The following is a description of a gene set: part of: Infectious disease Reactome Pathway: Parasitic Infection Pathways Parasitic infection pathways aim to capture molecular mechanisms of human parasitic diseases related to parasite adhesion to and invasion of human host cells and tissues, toxigenicity (interaction of parasite-produced toxins with the human host), and evasion of the host's immune defense.<br><br>Parasitic infection pathways currently include Leishmania infection-related pathways.<br><br>The parasites of the genus Leishmania are blood flagellates transmitted to humans by sandflies. Leishmania causes infections of the skin and mucous membranes that can spread to internal organs (viscera), such as liver, spleen and bone marrow. Visceral leishmaniasis is often fatal. studied in species Homo sapiens, and this is the list of marker genes: IGLV2-8, hly, MAPK1, IGLV1-40 (NCBI Gene Id 28825), IGLV11-55, CD163, VAV2, ELMO1, NOXA1, IGLC1, IGLC2, BAIAP2, IGHV3-7, ITPR2, GNG12, IGLV1-51, GNB2, ARPC2, NLRP3 (NCBI Gene Id 9558), IL1B, ABL1, NCKAP1L, ADCY8, BRK1, IGKV1-17, ADCY9, PRKACG, PYCARD, IGHV4-59, VAV3, CYFIP2, IGKV2-29, WNT5A, ADCY2, NCKAP1, CYBA, GNG5, ARPC3, HMOX1, SUGT1, PRKX, IGKV1-39, ARPC5, ELMO2, CD247, GNG11, PRKAR1B, WIPF3, WASF3, IGLV6-57 (immunoglobulin lambda variable 6-57), ABI1, CYFIP1, IL18, IGKV4-1, IGKV1-12, ARPC1A, ACTG1, CD3G, NFKB2, DVL2, LPG1G2, IGHG2, IGLC7, IGKV1-16, NCKIPSD, TXNIP, ADCY7, GNGT1, IGKV3-20, GNB3, GNG3, ADCY3, IGLV2-33, LYN, PRKACB, ADAM17, JUN, FCGR3A, MYH2, IGKV3-15, IGHV3-13, IGLV1-36, IGLV3-27, IGKV1D-16, NFKB1, CDC42, MYO9B, IGKC, SRC, ITPR1, RELA, GGT5, NOX1, PRKACA, VAV1, FCGR2A, IGLV7-43, IGKV2-28 (NCBI Gene Id 28921), ARPC4, IGKV3-11, P2RX7, AHCYL1, DVL3, GNAI3, WIPF2, FCGR1A, GNB4, DPEP2, GNAI2, IGLV3-12, IGLV5-45, IGHV3-30, IGKV1-33, IL1A, IGHV3-11, GNB1, IGKV1D-12, GNG4, IGLV3-21, CTSG, FYN, MYO5A, HCK (HCK proto-oncogene, Src family tyrosine kinase), NCK1, CREB1, IGLV4-3, ACTR2, RAC1, IGLV3-16, C3, SYK, BTK, GNAS, IGLV1-44, ADCY6, MEFV, FZD7, DPEP1, APP, IGLC6, IGHV4-34, IGLV3-25, YES1, MYH9, ARPC1B, IGKV2D-28, GNGT2, ACTB, IGLV10-54, DVL1, PSTPIP1 (proline-serine-threonine phosphatase interacting protein 1), DOCK1, GRB2, IGHV3-48, PLCG1, FURIN, IGLV3-1, IGHV4-39, MYO10, FGR, ABI2, IGKV1D-33 (immunoglobulin kappa variable 1D-33), WASF2, MAPK14, PLCG2, IGKV3D-20, WASL, IGHG4, ACTR3, MAPK8, IL6, ADORA2B, RHBDF2, IGHV7-81, GNAZ, ENTPD5, GNG10, GNG13, GGT1, NT5E, IGLV2-14 (immunoglobulin lambda variable 2-14), IGHV3-9, IGLV5-37, CASP1, ITPR3, IGHV, IGLV3-22, PRKAR2B (NCBI Gene Id 5577), IGHV3-23, GNG8, IGHG1, GNB5, IGHV3-53, IGLV2-23, IGLV1-47, IGHV1-46, IGLV3-19, WIPF1, IGHV2-5, IGHV3-33, IGLC3, MYO1C, GNAI1, ENTPD1 (NCBI Gene Id 953), IGLV8-61, IGLV4-69, P2RX4, TXN, CRK, IGKV2D-30, PTK2, IGHG3, PRKAR2A, IL10, CYSLTR2, NOXO1, IGKV1D-39, GNAT3 (G protein subunit alpha transducin 3), IGHV2-70, IGLV4-60, IGHV1-69, ADCY1, IGKV5-2, CYSLTR1, WASF1, IGKV1-5, IGLV2-18, PRKAR1A, IGLV7-46, IGKV2-30 (NCBI Gene Id 28919), C3AR1, GSDMD, IGLV, GNG2, WAS (NCBI Gene Id 7454), CALM1, ADCY4, IGLV2-11, GNG7, IGKV2D-40, PLK2, HSP90AB1, IGHV1-2, MAPK3 (NCBI Gene Id 5595), ADCY5